The following is a description of a gene set: species: Homo sapiens Iron accumulation in brain Human Gene Set: HP_IRON_ACCUMULATION_IN_BRAIN An abnormal build up of iron (Fe) in brain tissue., and this is the list of marker genes: VPS13A, PLA2G6, VPS41, REPS1 (RALBP1 associated Eps domain containing 1), TBCE, COASY, DLAT, PANK2, CP, WDR45, FA2H, FTH1, C19orf12, CRAT, FTL, NUDT2 (NCBI Gene Id 318)